Given this list of marker genes BAG4, FCER1G, PACS2, PPP2R5A, STX4, IFT80, TGFB1, GPC4, RHOQ, TTC8, PGRMC1, GOLPH3L, ROCK1, EHD4, VAMP5, CACNB3, CACNB2, AR, GABARAP, PDZK1, CACNG2, RDX, P2RY1, RILPL2, TUB, PPFIA1, STAC2 (SH3 and cysteine rich domain 2), RAPGEF6, RAP1A, IFNG, MIR223, GOLGA4, SQSTM1, TTC7A, TMEM59, NRXN1, C2CD5, NHERF4, SCP2, STAC, ADAM10, ABCA2, ARFRP1, SCN3B, ARL6IP5, OGT, EPB41L3, GAS6, VPS26B, PKP1, EHD2 (EH domain containing 2), NETO1, PRKCE, TSPAN14, FRMD8, CAMK2A, ANK3, AFDN, IQSEC2, RACK1, GPSM2, ZDHHC2, ATP1B1, RAB26, PRKCH, DPP10 (NCBI Gene Id 57628), SACM1L, LDLRAP1, PALS1, KRT18, HRAS, GPER1, ITGA3, TNIK, ZDHHC5, PID1, VIL1, TSPAN33, EPB41L2, RAB31, CAV3, ARL13B, SEC23A, GGA1, RAB10, GCC2, MISP, RAB11A, ARL3, AKAP5, KCNIP4, CACNA2D2, DAB2, RAB11FIP3, CDH1, GOLPH3, ATP2B4, VAMP3, GRIN2A, VPS4A, ARL13A, LARGE1, BSG, BBIP1, ZFYVE27, RAB7A, CSRP3, PRKG2, RAB38, FYB1, CCDC88A, KCNB1, ARF6, VTI1B, PACSIN1, EFR3B, CNPY4, C1QL3, ERBB4, NHERF1, PIP5K1A, NUBP1, JUP, SYS1, LRRC15, BLZF1, RABEP1, DLG4 (NCBI Gene Id 1742), IKBKB, RAPSN, CRB3, PIK3R2, MAP2K1, AKT1, PRAM1, GRIPAP1, NKD2, KIF2C, NHLRC1, ACSL3, EPM2A, GRIP2, FLOT2, EMP2 (NCBI Gene Id 2013), RAMP3, FGF13, SLMAP, ATP2C1, ACTB, F11R, HYCC1, SORL1, ARL6, MRAP, CDH2, KCNB2, GPHN, RAMP1, CLTC, APPL1, GORASP1, GRIP1, CAMK2D, PKP2, CACNG3, PHAF1, VPS35, SKAP1, RAB34, DLG1 (discs large MAGUK scaffold protein 1), GGA3, MAP7, DAG1, PPP1R9B (NCBI Gene Id 84687), SAPCD2, LHFPL4, TMED2, TMEM108, PKP3, TTC7B, GNAI1, ILK, NUMB, TSPAN5, PLEKHF1, AKT2, PICALM, CNIH3, CNST, ATP2C2, GIT1, LYPLA1, AP2M1 (NCBI Gene Id 1173), CSK, ABI3, SFN, EPHA3, RAB29 (NCBI Gene Id 8934), ZDHHC3, PIGW, FLNA, KCNIP3, ZDHHC22, TSPAN15, TRARG1, ROCK2, SLC4A1, ANK2, LRP6, S100A10, ZDHHC8, NSG1, EPHB2, NSF, PDPK1, TRAF6, MESD, BCL2L1, LYPD1, HYCC2, PACS1, EZR, GPR158, LAMA5, GBP1, ZDHHC4, ZDHHC23, RHOG, STXBP1, CAV1, ATP6AP1, RAMP2, EXOC5, TMEM88, ERRFI1, INS, CDK5, INPP5K, RAC1, GGA2, TESC, CLSTN1, DCHS1, LGALS3, EGFR, ADIPOQ, ERBB2, PTCH1, GAK, WDR19, WNK4, WNK1 (NCBI Gene Id 9872), ABCA12, RAB8A, EHD1, CLN3, SCARB2, CAMK2B, AP4M1, PREPL, RANGRF, MRAP2, NUMA1, FLOT1 (flotillin 1), VWC2, RAPGEF2, ACTN2 (NCBI Gene Id 88), TNF, EPB41, PRKCZ, TMEM150A, TREM2, EHD3 (EH domain containing 3), PIK3R1, WDR72, PLK1, RAP2A, RSC1A1, PRKCI, ITGB1BP1, GPC6, DPP6, OPTN, TMBIM1, SPTBN1, COMMD1, LRP1, RHBDF2, TNFRSF1A, BBS1, KIF5B, ITGB1, MACF1, WNT3A, PKDCC, SMURF1, MYO5A, NHERF2, MAL, GORASP2, LRRC7, ANK1, TPBG, IFT20, CD81, YPEL4, SLC1A1, PLS1, MYADM, STX3, GHSR, NPTX1, BBS2, SIRT6, SPTBN4, PPIL2, C1QL2, UMOD, LZTFL1, STAC3, ARHGAP44, ZDHHC7, EFCAB7, OLFM1, WNK3, LGI1, SNCA, CIB1 (NCBI Gene Id 10519), SORBS1, PIAS1, GOLGA7, CACNG7, MMP14, ATP1B3 (ATPase Na+/K+ transporting subunit beta 3), STX8, PDZK1P1, EIF4G1, AGR2, ARHGEF16, AMN, SEC16A, RILPL1, PRNP, CLIP3, PTPN9 (NCBI Gene Id 5780), RAB13, LYPLAL1, NETO2, VAMP2, VAMP8, EPHA2, PRPH2, DENND4C, FYB2, FCHO2, CPLX1, HSP90B1, RER1, VAMP4 (NCBI Gene Id 8674), CAMK2G, RAB11FIP2, SCRIB, ANXA13, EFR3A, NECTIN3, PALM, STX7, GRIN2C, KIF13A, here is a description of the gene set: Human Gene Set: GOBP_PROTEIN_LOCALIZATION_TO_CELL_PERIPHERY studied in species Homo sapiens A process in which a protein is transported to, or maintained in, the cell periphery.